The following is a description of a gene set: Human Gene Set: NAKAYA_MYELOID_DENDRITIC_CELL_FLUMIST_AGE_18_50YO_7DY_DN species: Homo sapiens Genes down-regulated in myeloid dendritic cell 7d vs 0d in young adults (18-50) after exposure to FluMist, time point 7D from publication Nakaya HI, Wrammert J, Lee EK, Racioppi L, Marie-Kunze S, Haining WN, Means AR, Kasturi SP, Khan N, Li GM, McCausland M, Kanchan V, Kokko KE, Li S, Elbein R, Mehta AK, Aderem A, Subbarao K, Ahmed R, Pulendran B (PMID 21743478) Here we have used a systems biology approach to study innate and adaptive responses to vaccination against influenza in humans during three consecutive influenza seasons. We studied healthy adults vaccinated with trivalent inactivated influenza vaccine (TIV) or live attenuated influenza vaccine (LAIV). TIV induced higher antibody titers and more plasmablasts than LAIV did. In subjects vaccinated with TIV, early molecular signatures correlated with and could be used to accurately predict later antibody titers in two independent trials. Notably, expression of the kinase CaMKIV at day 3 was inversely correlated with later antibody titers. Vaccination of CaMKIV-deficient mice with TIV induced enhanced antigen-specific antibody titers, which demonstrated an unappreciated role for CaMKIV in the regulation of antibody responses. Thus, systems approaches can be used to predict immunogenicity and provide new mechanistic insights about vaccines., and this is the list of marker genes: ERAP1, XPO6, KPNA2, MRPS10, MSRB2, C9orf78, ZNF211, ZNF337, FAM120A, SLC29A1, BCAT1, ZMIZ2, PTRH2, IFIH1, TNFRSF25, ZNF821, SMAD4, RING1, IGKC, ICOSLG, ZC3H14, SLC48A1, CCR6, TICAM1 (NCBI Gene Id 148022), NAA40, MASP2, RAB27A, ZFP64, ZNF264, ACSL1, TFIP11, NCAM1, OGT, CYRIB, G6PC3, ZNF155, NIPSNAP1, AMZ2, ASAH1, XRCC1, TM2D1, CES2, UBTF, DDB2, MYOF (NCBI Gene Id 26509), ZBTB17, PTTG1, KPNA6, TCF7L1, CRAT, ARIH1, SP140, BAG3, PPM1D, PSEN2, MDM2, UBXN7, PEX7, CRIPT, CLCN5, GPR107, NAA16, ATF7IP, TFF3, IGF2R, ZNF589, H2AZ2, UBE2B, MAP1A, ZBTB18, DCAF7, STAT3, KRAS, AKIP1, IFI44, MTPAP, TENM1, KMO, PTCD3, PSIP1, FXN, PPARD, RALGAPB, DUOX1, ZBTB40, GBE1, SMC4, MARCHF6 (NCBI Gene Id 10299), PLA2G7, TMEM106C, MAL, CLEC11A, ARHGAP1, LMO4, NRP1, COPB1, GOT1, MMP11, TMEM50B, SAR1A, ZNF706, PTK2, INSM1, RCN1, SMAGP, CASP4, SLC25A24, MRS2, BNIP1, TFEC, GEMIN2, DDX19A, CASP9 (caspase 9), ABL1, SRRD, APOBEC3F, CDK10, MID1, XPO4, SNRNP35, QDPR, PCYOX1L, E2F5, STAT1, NUP37, PDCD2, CDK5R1 (cyclin dependent kinase 5 regulatory subunit 1), VEGFA, NFKB2, FCMR, G0S2, ADAMTS2, ZFX, PCIF1, KIF1C, EI24, CD22, ENPP2, TFRC, ALDH6A1, MTMR4, RAB28, MALT1, CPT1A, CREM, SF1, SNRPB, NPAT, OASL, CRTC3, PDLIM5, IFIT5, PMS2P3, RANBP6, TTLL3, TSPAN13, ATP2C1, SRI, CDR1, KIAA0040, XPNPEP3, TCAF1, FBXO7, APPL2, CFAP74, TCEAL2, POLR2C, HMGN4, WAC, NR3C1, CHUK, SNUPN, OGFOD3, TCF7L2, MAP7, RGL1, CPPED1, VPS26C, AGRN, KPNA3 (karyopherin subunit alpha 3), RRP1B, SFRP1 (secreted frizzled related protein 1), HEMK1, PIK3CA, NOC3L, SAE1, TTBK2, ARMC9, ZSCAN12, IL15, PRKRIP1, C2orf68, NUP153 (NCBI Gene Id 9972), POLR3D, CLPX, TMEM268, LPAR1, TMEM41B, SMARCA2, LMBR1L, GLRX2, KRT86, ZNF672, SIAH1, KLHL7, VRK3, NDEL1, PIGG, TUT4, NUAK2, ELMO2, TAF1C, PBX2, RS1, SRSF7, KIZ, PJA1, DUT, PIK3C3, LY6G5C, CHN2, SOX4, DDX60, DGKE, NCAPG, SEC31B, SPNS1, CMC2, JAK3, SLC25A20, SZRD1, THAP12, ABCF2, TOE1, RAB20, LY75, FLOT1, PCDHGC3, ASAP2, CCDC92, AKAP6, TMEM147, SLC7A11, LAT, GNPDA1, SENP5, PRKD1, CUL5, TRIB2, ENTPD4, TRIM38, SPATA2L, DZIP3, SLF2, SYPL1 (NCBI Gene Id 6856), ARFGAP2, APOBEC3G, EP400, DTNA, YAF2, RCOR3, TMCO1, GBP1, COBLL1, FBXW7, ELK3, NR4A3